Given this list of marker genes Fgfr1, Rgcc, Cd59a, Fgfr4, Wnt11, here is a description of the gene set: Mouse Gene Set: GOBP_NEGATIVE_REGULATION_OF_FIBROBLAST_GROWTH_FACTOR_PRODUCTION species: Mus musculus Any process that decreases the rate, frequency or extent of the appearance of a fibroblast growth factor due to biosynthesis or secretion following a cellular stimulus, resulting in an increase in its intracellular or extracellular levels.